The following is a description of a gene set: studied in species Homo sapiens Human Gene Set: WP_17Q12_COPY_NUMBER_VARIATION_SYNDROME 17q12 copy number variation syndrome, and this is the list of marker genes: PEX12, NEUROD2, CCL18, TBC1D3B, ASIC2, TADA2A, HEATR9, AP2B1, GRB7, NLE1, STARD3, FBXO47, LYZL6, TBC1D3C, TBC1D3E, CISD3, MRM1, SLFN12, TBC1D3H, RPL23, CCL4L2, CCL8, CCL13, RDM1 (RAD52 motif containing 1), HNF1B, CCL3, LASP1, TMEM132E, ARL5C, SPMAP1, MYO19, PIGW, DDX52, CWC25, CCL7, ZNF830, PNMT, UNC45B, SLFN11, CCT6B, PPP1R1B, PLXDC1, CCL2, CCL11, CCL3L3, IKZF3, C17orf78, TBC1D3K, SRCIN1, SLFN13, ACACA, RFFL, SLC35G3, MLLT6, TBC1D3, PGAP3, RASL10B, LHX1, MIEN1, TEC, CCL4 (C-C motif chemokine ligand 4), RAD51D, TMEM132E-DT, DUSP14, TBC1D3I, SYNRG, C17orf50, CDK12, FNDC8, GPR179, CCL16, TBC1D3L, GGNBP2, ERBB2, MRPL45 (NCBI Gene Id 84311), GAS2L2 (growth arrest specific 2 like 2), SOCS7, CCL15, SLFN14, DHRS11, TCAP, PIP4K2B, STAC2, MED1, TBC1D3G, MMP28, EPOP, PCGF2, CCL5, CCL1, TAF15, LIG3, ARHGAP23, CCL14, FBXL20, AATF, ZNHIT3, SLFN5, CACNB1